The following is a description of a gene set: Human Gene Set: GOBP_GLYCOLIPID_CATABOLIC_PROCESS studied in species Homo sapiens The chemical reactions and pathways resulting in the breakdown of glycolipid, a class of 1,2-di-O-acylglycerols joined at oxygen 3 by a glycosidic linkage to a carbohydrate part (usually a mono-, di- or tri-saccharide)., and this is the list of marker genes: GALC, GLB1, LCT, SMPD1, M6PR, NEU1, GBA1, NEU4, NEU3, GBA2, PNLIPRP2, MIR16-1 (NCBI Gene Id 406950), NAGA, ENPP7, GBA3, GM2A, MIR127, FUCA1, NEU2, PRKCD, SUMF1, HEXA, SCARB2, HEXB, MIR195, GLA